Given this list of marker genes Ap1b1 (adaptor protein complex AP-1, beta 1 subunit), Pola2, Orai2, Spn, Barhl1, here is a description of the gene set: Genes predicted to be targets of miRBase v22 microRNA mmu_miR_673_3p in miRDB v6.0 with MirTarget v4 prediction scores > 80 (high confidence targets). studied in species Mus musculus from publication Chen Y, Wang X (PMID 31504780) Mouse Gene Set: MIR_673_3P